The following is a description of a gene set: Human Gene Set: ROSS_AML_OF_FAB_M7_TYPE Contemporary treatment of pediatric acute myeloid leukemia (AML) requires the assignment of patients to specific risk groups. To explore whether expression profiling of leukemic blasts could accurately distinguish between the known risk groups of AML, we analyzed 130 pediatric and 20 adult AML diagnostic bone marrow or peripheral blood samples using the Affymetrix U133A microarray. Class discriminating genes were identified for each of the major prognostic subtypes of pediatric AML, including t(15;17), t(8;21), inv(16), MLL chimeric fusion genes, and cases classified as FAB-M7. When subsets of these genes were used in supervised learning algorithms, an overall classification accuracy of more than 93% was achieved. Moreover, we were able to use the expression signatures generated from the pediatric samples to accurately classify adult de novo AMLs with the same genetic lesions. The class discriminating genes also provided novel insights into the molecular pathobiology of these leukemias. Finally, using a combined pediatric data set of 130 AMLs and 137 acute lymphoblastic leukemias, we identified an expression signature for cases with MLL chimeric fusion genes irrespective of lineage. Surprisingly, AMLs containing partial tandem duplications of MLL failed to cluster with MLL chimeric fusion gene cases, suggesting a significant difference in their underlying mechanism of transformation. Top 100 probe sets for pediatric acute myeloid leukemia (AML) subtype FAB M7 (also known as acute megakaryoblastic leukemia, AMKL). studied in species Homo sapiens from publication Ross ME, Mahfouz R, Onciu M, Liu HC, Zhou X, Song G, Shurtleff SA, Pounds S, Cheng C, Ma J, Ribeiro RC, Rubnitz JE, Girtman K, Williams WK, Raimondi SC, Liang DC, Shih LY, Pui CH, Downing JR (PMID 15226186), and this is the list of marker genes: DNM3, TEK, CD164, ITGA2B, VPS37B, GATA2, TAL1, DNAJC9, PLOD2, MRPS12, RYR3, FADS2, TFR2, RHAG, ANK1, PTGS1, NET1, LAT, ATP5MJ, FHL2, HLTF, SOD1, GP1BA, GJA4, RASA1, MYL4, PDCD10, DLC1, DNAJC6, PNMT, PCCB, CMAS, ABCC4, ZMYND8, PCDH9, TIMP3, PSMD6, KCNH2, LAPTM4B, NEO1, BEX3, TNIK (TRAF2 and NCK interacting kinase), KLF1, UROD, APOC1, STXBP6, APOE, SLC39A4, PRUNE1, MINPP1, ALDH1A1, SQLE, ARMC8, BMP2K, CTNNBL1, ICAM4, SERPINI1, DRAP1, CUTA, KEL, TPM1, RDX (radixin), PROS1, GATA1, NDUFB6, HIGD1A, GP1BB, MYH10, PDLIM5, CAVIN2